Given this list of marker genes NDUFS2, NDUFB8, DMAC2L (NCBI Gene Id 27109), ATP5MC1, NDUFB6, ATP5PO, NDUFB5, ATP5ME, NDUFB9, NDUFS5, NDUFS4, ATP5F1B, NDUFV2, NDUFA4L2, NDUFC1, ATP6AP1, MT-ND4L, ATP5PB, MT-ND2, ATP5F1A, MT-ND3, NDUFA4, ATP6AP2, NDUFA6, ATP5MF, NDUFS6, ATP5MG, MT-ND5 (mitochondrially encoded NADH:ubiquinone oxidoreductase core subunit 5), NDUFB1, MT-ND1, ATP5PF, MT-ATP6, NDUFAB1, NDUFA7, NDUFV3, GZMB, NDUFS7, ATP5PD, NDUFA2, NDUFB2, NDUFA9, NDUFB7, NDUFB4, ATP5F1D, NDUFB10, ATP5MC2, NDUFA5, NDUFA3, NDUFC2, NDUFV1, NDUFS3, NDUFS8, NDUFA10, NDUFA11, ATP5F1E, NDUFS1, MT-ND6, ATP5MC3, MT-ND4, NDUFA8, here is a description of the gene set: Oxidative phosphorylation Human Gene Set: WP_OXIDATIVE_PHOSPHORYLATION studied in species Homo sapiens